Given this list of marker genes MT4, MT1A, HMOX1, MT1F, MT1HL1, GOT1, HAAO, NPC1, PTH, MT-CYB (NCBI Gene Id 4519), MT1DP, MTF1, SOD2, MT1B, SLC34A1, CYP1A2, ABCB6, CYBB, PRNP, HSF1, MT1E, CDK1, SUMO1, MT2A, MT1G, SLC11A1, TERT, ALAD, CAT, DAXX (death domain associated protein), GCLC, ABCB1 (ATP binding cassette subfamily B member 1), MT3, MT1X (metallothionein 1X), PCNA, HESX1, MAPK9, KIT, SLC30A1, SOD1, SLC39A8, MT1H, CPA1, GSS, CER1, MT1M, PPP5C (NCBI Gene Id 5536), GPI, here is a description of the gene set: Human Gene Set: GOBP_RESPONSE_TO_CADMIUM_ION studied in species Homo sapiens Any process that results in a change in state or activity of a cell or an organism (in terms of movement, secretion, enzyme production, gene expression, etc.) as a result of a cadmium (Cd) ion stimulus.